Given this list of marker genes MAPK8IP1, PNP, CRHR2, DROSHA, FILIP1L, MCL1, LAMP5, SFPQ, TPSD1, RPL27A, CD86, PSTPIP1, GSPT1, ITIH1, MEX3C, SLC13A2, ZBTB43, DEFA6, MT4, GOLGA2P5, FTH1P5, IGF1R, SRSF3, HCG4B, SYN3, IGFBP1, GIT1, INSIG1, BCAM, LIMD1, ZNF614, GDPD2 (NCBI Gene Id 96453), BTAF1 (B-TFIID TATA-box binding protein associated factor 1), CYP2B7P, RGS2, TWSG1, RALGAPA1, SLC7A7, HRH3, PLAUR, GZMH, F2RL3, MPDZ, PABPC3 (poly(A) binding protein cytoplasmic 3), HNRNPH1, SH2D3A, GMPS, G0S2, CDKN1A, DNAJB1, H2BC10, RAD9A, GJB4 (gap junction protein beta 4), LRRC49, PRRC2A (proline rich coiled-coil 2A), HECW1, SLC30A3, DDIT3, LDLRAP1, SYT12, CLEC11A, TEX13A, H3C11, POLR1G, TEX13B, INSL6, TOP3A, TPM1, KPNA2, CCDC144A, NRXN1, SELL, TCEAL4, INSL3 (NCBI Gene Id 6020), ELAVL3, UPK3A, SLC49A3, SH3D21, TTC22, MYO1B, DNAI2, UBE2D1, CRX, CD6, MAP1A, DUSP5, OSMR, BHLHE40, HOXD10, SP3P, IL3, CYTIP, RNF139, CLN8, FIG4, STX4, KPTN, PER1, SERPINE2, EFNA3, COL4A5, FOSL2, AOPEP, MGAT4A, MAGOH2P, RAB26, RGS16 (NCBI Gene Id 6004), C11orf71, SMPX, RORA, DUSP10, LARS1, ZNF83, ALOX12B, PMP2, PMS2P5, N4BP2L1, DGKE, ALOX15B, ERBB2, BCAS4, TBC1D15, SLC4A10, ITGA3, CRYAA, HAT1, OSBP, RBBP6 (NCBI Gene Id 84712), STEAP1, POLR1D, ZNF682 (NCBI Gene Id 91120), SEMA7A, SNRPG, CUL3, SMAD9, ZNF267, NLRP1, MLLT11, MEFV, CALR, RPS27, TEX30, SMG7-AS1, HNRNPA2B1, IFI44L, PHLDA1, IL7, FKBP4, CP, OCA2 (OCA2 melanosomal transmembrane protein), CCL17, USP32 (NCBI Gene Id 84669), EIF4H, IPO13, TMEM70, TCN2, NAE1, CUL2, LYVE1, SUSD4 (NCBI Gene Id 55061), GCKR, SLC12A8, SPINK1 (NCBI Gene Id 6690), BACH1, ALX3, GPR45, ATF7, AGRP, RUSC2, CHRND, LAD1, KRBOX4, NDUFAF5, DCTN6, NOP16, FABP2, SCEL, SMARCA5, SEMA5A, SOCS5, ATAD2B, SOX12, CENPA, TIPIN, MAPK13, JUN, ABI3BP, MRPS2, MPDU1, BNIP1 (NCBI Gene Id 662), RARRES2 (NCBI Gene Id 5919), IFNA14, RUFY3, LINC01711, RTN1, RBM23, HSPE1, SPC25, NAPA, SNAI1, here is a description of the gene set: In the present study we used Affymetrix oligonucleotide microarrays to produce gene transcription profiles for the major leukocyte types in humans. This comprehensive dataset enabled us to not only establish which genes were expressed in each leukocyte type, but also which genes were expressed in each subset after activation. The used of a comprehensive dataset of gene profiles from all the major human leukocyte subsets enabled a novel and powerful means for identification of genes associated with single leukocyte subsets, or different immune paradigms. from publication Jeffrey KL, Brummer T, Rolph MS, Liu SM, Callejas NA, Grumont RJ, Gillieron C, Mackay F, Grey S, Camps M, Rommel C, Gerondakis SD, Mackay CR (PMID 16474395) Genes down-regulated in comparison of untreated eosinophils versus eosinophils treated with PMA at 2 h. species: Homo sapiens Human Gene Set: GSE3982_CTRL_VS_PMA_STIM_EOSINOPHIL_DN